The following is a description of a gene set: Mouse Gene Set: BYSTRYKH_HEMATOPOIESIS_STEM_CELL_FGF3 studied in species Mus musculus We combined large-scale mRNA expression analysis and gene mapping to identify genes and loci that control hematopoietic stem cell (HSC) function. We measured mRNA expression levels in purified HSCs isolated from a panel of densely genotyped recombinant inbred mouse strains. We mapped quantitative trait loci (QTLs) associated with variation in expression of thousands of transcripts. By comparing the physical transcript position with the location of the controlling QTL, we identified polymorphic cis-acting stem cell genes. We also identified multiple trans-acting control loci that modify expression of large numbers of genes. These groups of coregulated transcripts identify pathways that specify variation in stem cells. We illustrate this concept with the identification of candidate genes involved with HSC turnover. We compared expression QTLs in HSCs and brain from the same mice and identified both shared and tissue-specific QTLs. Our data are accessible through WebQTL, a web-based interface that allows custom genetic linkage analysis and identification of coregulated transcripts. Genes whose expression is coregulated with that of FGF3 in hematopoietic stem cells (HSC). from publication Bystrykh L, Weersing E, Dontje B, Sutton S, Pletcher MT, Wiltshire T, Su AI, Vellenga E, Wang J, Manly KF, Lu L, Chesler EJ, Alberts R, Jansen RC, Williams RW, Cooke MP, de Haan G (PMID 15711547), and this is the list of marker genes: Map2k6, Bmp8a, Pknox1, Bmp8b, Pou5f1, Sh3rf1, Efnb1, Efnb3